Given this list of marker genes PAK2, CASP3, here is a description of the gene set: studied in species Homo sapiens part of: Apoptotic execution phase Reactome Pathway: Stimulation of the cell death response by PAK-2p34 In response to stress signals, the p21-activated protein kinase PAK-2 stimulates a cell death response characterized by increased cell rounding and apoptotic chromatin condensation (see Jakobi et al., 2003). PAK-2 is proteolytically cleaved by caspase-3 producing a constitutively active fragment, PAK-2p34. Following cleavage, PAK-2p34 is autophosphorylated at Thr 402 and transported to the nucleus where it accumulates due to the loss of its nuclear export signal motif. The activity of PAK-2p34 appears to be regulated both by proteosomal degradation and by association with the GTPase-activating protein PS-GAP/ RHG-10. This interaction inhibits the kinase activity of PAK-2p34 and changes the localization of PAK-2p34 from the nucleus to the perinuclear region. PAK-2p34 may function in the down-regulation of translation initiation in apoptosis through phosphorylation of Mnk1 (Orton et al.,2004).